Given this list of marker genes TRAF3, NCKAP1L (NCBI Gene Id 3071), SNORA31, TICAM1, TBK1, STAT1, IRF3, TLR3, HYOU1, UNC93B1, here is a description of the gene set: Herpes simplex encephalitis studied in species Homo sapiens Human Gene Set: HP_HERPES_SIMPLEX_ENCEPHALITIS Infection of the brain parenchyma with herpes simplex virus, resulting in inflammation of the brain parenchyma with neurologic dysfunction.